Given this list of marker genes Shh, Bmpr1a, Zbtb17, Elf5, Lhx1, Fzd7, Pou5f1, Grhl3, Ets2, Sall1, Tpt1, Ctnnb1, Nf2, L3mbtl2, Amer2, Foxa2, Vps52, Epb41l5, Erf, here is a description of the gene set: The process whose specific outcome is the progression of the ectoderm over time, from its formation to the mature structure. In animal embryos, the ectoderm is the outer germ layer of the embryo, formed during gastrulation. Mouse Gene Set: GOBP_ECTODERM_DEVELOPMENT species: Mus musculus